The following is a description of a gene set: Human Gene Set: KEGG_MEDICUS_REFERENCE_TNFSF10_RIPK1_3_SIGNALING_PATHWAY studied in species Homo sapiens TNFSF10-RIPK1/3 signaling pathway. Pathway ID: N01631. Pathway type: Reference. Pathway class: nt06527 Necroptosis. Pathway Definition from KEGG: TNFSF10 -> TNFRSF10 -> (RIPK1+RIPK3), and this is the list of marker genes: RIPK3, TNFRSF10B, RIPK1, TNFSF10, TNFRSF10A